Given this list of marker genes GULP1, KLF6, CREB5, PARD3, SOX6, TNIK, ABLIM1, NRP1, CLSTN2, SLC13A1, GNAQ, IGF1R, ARGLU1, PAX8 (paired box 8), PDLIM5, PTPRK (protein tyrosine phosphatase receptor type K), GMDS-DT, ADAMTS9-AS1, FHIT, ANK3, EXT1, PTK2, AKAP12, LINC01320, SLC2A9, BNC2, ITGAV, ARHGAP26, KANK1, CNTN4, PTPRM, NRG3, SYNE2, SLC17A1, RERG (RAS like estrogen regulated growth inhibitor), TRABD2B (NCBI Gene Id 388630, TraB domain containing 2B), ZBTB16, SPATS2L, PLCL1, PDE8A, RHOBTB1, SDK1, KANSL1, FAF1, LPP, NFIB, WDFY3, DCDC2, UGT2B7, PPFIBP1, PDE7A, AKAP13, RBPMS, CDK14, ERRFI1, GALNT14, ITGB8, AOPEP, VPS13A, OXR1, PLEKHA5, EPB41L4A, RERE, PTPRG, CCDC198, BCL2, CAMKMT, TMEM178B, RASAL2, CUX1, TTC28, SLC16A12, SASH1, DNAH14 (NCBI Gene Id 649123), MAPK10, FOXP2, WWC1, CNKSR3, FARP1, COL4A2, MEF2A, PTPRD, GLS, BDP1, FMNL2, TCF12, ANKIB1, NHS, RETREG1, ITSN1, PKHD1, NOX4, NFIA (nuclear factor I A), MBD5, NBEA, L3MBTL4, TRIO, DLG1, RNF213, PRUNE2, GLIS3, P3H2, ALPK2, FHOD3, PARD3B, PRKN, NCKAP5, BABAM2, EPS8, BICC1, LRP2, ANKRD26, LRMDA, DGKH, VWA8, DANT2, CALD1, COL18A1, SSH2, GPC6, ACSM3, KIAA1217, UBE2E2, PTH2R, ACSM2A, WWOX, AGBL4, PAM, ZBTB20, EXOC4, DLG2, EIF4G3, FTX, PDE4D, ACSM2B, AGAP1, COL4A1, ARHGAP6, CDKAL1, PICALM, SCMH1, STOX2, CDH6, MAML2, RAPGEF2, MACC1, KLF12, SORBS2, CLIC4, ZFAND3, ZBTB38, PPP1R9A, DYNC2I1, DIP2C, SBF2, SHROOM3, DLGAP1, KANSL1L, CRIM1, RHEX, PLXDC2, RBMS3, SUMF1, SIPA1L1, TPM1, FKBP5, RORA, SEMA5A, NLGN1, PATJ, NEAT1, KCNJ15, MAST4, SAMD4A, SVIL, NTN4, here is a description of the gene set: from publication Lake BB, Chen S, Hoshi M, Plongthongkum N, Salamon D, Knoten A, Vijayan A, Venkatesh R, Kim EH, Gao D, Gaut J, Zhang K, Jain S (PMID 31249312) studied in species Homo sapiens Human Gene Set: LAKE_ADULT_KIDNEY_C4_PROXIMAL_TUBULE_EPITHELIAL_CELLS_S2